The following is a description of a gene set: To obtain insight into the genetic basis of the increase of functional activity of memory B cells over time, we compared the gene expression profiles of day 7 and day 40 NP-specific/IgG1 memory B cells, GC B cells and plasma cells in immunized WT mice and naïve B cells, before and after activation in vitro. Genes down-regulated in follicular B cells versus marginal zone B cells. species: Homo sapiens from publication Kaji T, Ishige A, Hikida M, Taka J, Hijikata A, Kubo M, Nagashima T, Takahashi Y, Kurosaki T, Okada M, Ohara O, Rajewsky K, Takemori T (PMID 23027924) Human Gene Set: GSE11961_FOLLICULAR_BCELL_VS_MARGINAL_ZONE_BCELL_DN, and this is the list of marker genes: IL17RD, DOCK6, GAS2L1, CRYGN (NCBI Gene Id 202871), FCRLA, PRKAR1A (protein kinase cAMP-dependent type I regulatory subunit alpha), NUDT9, ZNF606, TXNDC17, EFNB1, MAP3K20, SLC7A8, CGA, C1orf141, CFH, SOX4, SPINK4, UBFD1, WDR62, CLDN19, FST, BRDT, CAT, PITPNM1, IL12B, INSR, SLC35B1, HRH3, DTNB, FZD1, LTBP2, SERPINE2, NTRK1, RHBDF1, P3H2, INPP1, SLC33A1, FAM86B2, PDZK1IP1, RIPOR1, CHPF2, TEX264 (NCBI Gene Id 51368), ADH7, ZCCHC4, GNA15, TREML4, PBX1, MPZL2, AGMAT, TNFAIP6 (TNF alpha induced protein 6), SNED1, RECK, FHIP1B, FBXO41, MXRA7, SLC11A1, MIA, BCL6, TUBB6, ITLN1, MIR1915HG, IFNB1, ANXA10, PADI3, CD8A, THSD7A, UBE2M, OLFM1, ODC1 (ornithine decarboxylase 1), MAN2A1, PMP22 (peripheral myelin protein 22), VSIG10L, APOA4 (apolipoprotein A4), SLC8B1, PREB, PPP1R15B, LRFN3, IFNGR1, RABGGTB, UBA6, AMIGO1, HPS5, CABP4, HBB, LMX1A, RIPK1, RHOBTB1, FOXN1, TMC7, ITGB5, GTF2H1, PRODH, UNC80, RAB39B, LHFPL3, BTBD3 (NCBI Gene Id 22903), TRIM17, EXTL2, MANF, ADCY6, GPX7 (NCBI Gene Id 91407), TSPAN15, GPRC5C, SDC3, VHL, UQCC1, GPR150, RRBP1, NAALAD2, KCNA7, ECE1, KLHL35, ITGA6, SPMIP8, OPRD1, ABCA12, PLAAT5, CFAP251, COL24A1, CITED2, DDOST, UBQLN3, CDK3, MYOM3, TNFRSF10A, BARHL1, ERCC6L, PPP1R26, USP13, USP43, RCBTB2 (NCBI Gene Id 1102), MRPL42, FCGRT, PTGIS, CRPPA, ADRA1A, UBQLNL, ATP6V0A2, SLC9A9, STAB1, STARD10, DHRS11, SIGMAR1, ARL4A, LENG9, BNIPL, RALA, OCSTAMP, ASL, DSPP, ATP12A, NELL2, GALNT2, LITAF, OSBPL3, FAM241A, HABP4, GPR176, PRMT8, SLC5A2, PHOX2B, ZDHHC2, POLM, KALRN, SLC25A47, ZNF318, GLOD4, NPY4R, SOD1, PCDHB12, ZC3H12D, TIAM1, CACNB2, CPM, SOX6, FSD1, CRAT, CCDC184, TUBB2B (NCBI Gene Id 347733), OR2C1, TMEM270, CD81, PDE3A, ENPP4, ADORA3, DNAJB9, TRPC7, SULT1A1, PDE8A, HEBP2 (NCBI Gene Id 23593), ARHGAP22, PAX4, LRRC1, GATA2, SLC39A1, BCL6B, CPQ (NCBI Gene Id 51670), GFAP, ATP5MC3, CNGA1